Given this list of marker genes DKK4, FZD4, WNT3A, CTBP2, PPP2R5C, PPP2R5A, DKK1, PPP2CA, TNKS, CSNK1A1, AXIN1, FZD6, CTNNB1, PPP2R5D (NCBI Gene Id 5528), CTBP1, LRP5, PPP2R5B, PPP2R1A, TCF7L2, PPP2R1B, APC, PPP2CB, FZD5, RNF43, KREMEN2, PPP2R5E, PORCN, LRP6, TNKS2, FZD8, AMER1, GSK3B, DKK2 (dickkopf WNT signaling pathway inhibitor 2), KREMEN1, here is a description of the gene set: species: Homo sapiens The WNT signaling pathway has been linked with cancer ever since the identification of the first WNT as a gene activated by integration of mouse mammary tumor virus proviral DNA in virally-induced breast tumors. The most well known example of aberrant WNT signaling in cancer is in colorectal cancer, where an activating mutation in a WNT pathway component is seen in 90% of sporadic cases. Inappropriate WNT pathway activation has also been implicated in most other solid human cancers but is not always associated with mutations in WNT pathway components.<br>Both tumor suppressors and oncogenes have been identified in the so-called canonical WNT pathway, which regulates WNT-dependent transcription by promoting the degradation of beta-catenin in the absence of ligand. Loss-of-function mutations in the destruction complex components APC, Axin and AMER1 and gain-of-function mutations in beta-catenin itself cause constitutive signaling and are found in cancers of the intestine, kidney, liver and stomach, among others. WNTs and WNT pathway components are also frequently over- or under-expressed in various cancers, and these changes are correlated with epigenetic regulation of promoter activity. In some contexts, both the canonical and non-canonical WNT signaling, which governs processes such as cell polarity and morphogenesis, may also contribute to tumor formation by promoting cell migration, invasiveness and metastasis. part of: Diseases of signal transduction by growth factor receptors and second messengers Reactome Pathway: Signaling by WNT in cancer